Given this list of marker genes Arl16, Pilra, Ift43, Usp34, Elavl1, Hunk, Fn1, here is a description of the gene set: Mouse Gene Set: MIR_6416_5P from publication Chen Y, Wang X (PMID 31504780) studied in species Mus musculus Genes predicted to be targets of miRBase v22 microRNA mmu_miR_6416_5p in miRDB v6.0 with MirTarget v4 prediction scores > 80 (high confidence targets).